The following is a description of a gene set: Human Gene Set: GOBP_POSITIVE_REGULATION_OF_AXONOGENESIS studied in species Homo sapiens Any process that activates or increases the frequency, rate or extent of axonogenesis., and this is the list of marker genes: ZFYVE27, SHOX2, PLXNB2 (NCBI Gene Id 23654), SLITRK1, MAP2K2, PLXNB1, MAP1B, AMIGO1, TRPV2, LIMK1 (NCBI Gene Id 3984), RND2, POU4F2, PAK1, WNT3A, TRPC5, METRN, EFNA5, DISC1, LPAR3, ANAPC2 (anaphase promoting complex subunit 2), MAP3K13, PLXNB3, SEMA7A, GOLGA4, MAPT, VEGFA, SHTN1, SMURF1, TRAK1 (NCBI Gene Id 22906), IST1, TIAM1, ZEB2, ROBO1, NGF, ROBO2, NTRK3 (neurotrophic receptor tyrosine kinase 3), MAP6, BMPR2, CHODL, SEMA4D, SLIT2, SKIL, PAFAH1B1, TIAM2, NRP1, SEMA5A, CDKL5, PLXNC1, TNFRSF12A, L1CAM, NRDC, CDH4, FN1, CRABP2, STK25, MACF1 (microtubule actin crosslinking factor 1), BRAF (NCBI Gene Id 673), DSCAM, MEGF8, NTN1, GDI1, NIN, BCL11A, RUFY3 (RUN and FYVE domain containing 3), MAP2K1, BDNF, ADCY10 (adenylate cyclase 10), ISLR2, NEFL, STK11, PLXND1, NTRK2, SRF, ADNP, WNT3, CXCL12, TWF2